The following is a description of a gene set: Reactome Pathway: Sema4D mediated inhibition of cell attachment and migration part of: Sema4D in semaphorin signaling electronically inferred by orthology from the curated human pathway This event has been computationally inferred from an event that has been demonstrated in another species.<p>The inference is based on the homology mapping from PANTHER. Briefly, reactions for which all involved PhysicalEntities (in input, output and catalyst) have a mapped orthologue/paralogue (for complexes at least 75% of components must have a mapping) are inferred to the other species. studied in species Mus musculus, and this is the list of marker genes: Rnd1 (Rho family GTPase 1), Sema4d, Rras